Given this list of marker genes Phf2, Rsbn1, Phf8, Jmjd6, Kdm7a, here is a description of the gene set: studied in species Mus musculus Catalysis of the removal of a methyl group from a modified lysine residue of the histone H4 protein. This is a dioxygenase reaction that is dependent on Fe(II) and 2-oxoglutarate. Mouse Gene Set: GOMF_HISTONE_H4_DEMETHYLASE_ACTIVITY